Given this list of marker genes Slc13a5, Slc25a1, Sfxn5, Umod, Slc13a3, here is a description of the gene set: Mouse Gene Set: GOBP_TRICARBOXYLIC_ACID_TRANSPORT species: Mus musculus The directed movement of tricarboxylic acids into, out of or within a cell, or between cells, by means of some agent such as a transporter or pore.